Given this list of marker genes Prdx1, Prep, Septin4, Ndufb5, Sod1, Hba-a1, Btg3, Ndufc1, Hspe1, Hexb, Cct6a, M6pr, Mt1, Hba-a2, Map2k1, Actb (actin, beta), Clk1, Itpr1, Ppp1r7, Tbca (NCBI Gene Id 21371), Ndufa1, Casp6, Csf1r, Hsd17b4, Thy1, Atp5f1c, Psma6, Rps12, Hbb-bs, Cox7a2, Tpp1, Tpd52, Ctss (cathepsin S), Akr1a1, Psmd14, Gas5, Snx2, Atp5mg, Map4, Anp32b, Sst, Pafah1b1, C1qbp, Ppa1, Atp5mk, Atp5po, Rpl17, B2m, Atp5if1, Psma4, here is a description of the gene set: Mouse Gene Set: JIANG_AGING_HYPOTHALAMUS_UP Up-regulated in the hypothalamus of aged (22 months) BALB/c mice, compared to young (2 months) controls from publication Jiang CH, Tsien JZ, Schultz PG, Hu Y (PMID 11172053) A better understanding of the molecular effects of aging in the brain may help to reveal important aspects of organismal aging, as well as processes that lead to age-related brain dysfunction. In this study, we have examined differences in gene expression in the hypothalamus and cortex of young and aged mice by using high-density oligonucleotide arrays. A number of key genes involved in neuronal structure and signaling are differentially expressed in both the aged hypothalamus and cortex, including synaptotagmin I, cAMP-dependent protein kinase C beta, apolipoprotein E, protein phosphatase 2A, and prostaglandin D. Misregulation of these proteins may contribute to age-related memory deficits and neurodegenerative diseases. In addition, many proteases that play essential roles in regulating neuropeptide metabolism, amyloid precursor protein processing, and neuronal apoptosis are up-regulated in the aged brain and likely contribute significantly to brain aging. Finally, a subset of these genes whose expression is affected by aging are oppositely affected by exposure of mice to an enriched environment, suggesting that these genes may play important roles in learning and memory. studied in species Mus musculus